The following is a description of a gene set: species: Homo sapiens Human Gene Set: PID_THROMBIN_PAR4_PATHWAY PAR4-mediated thrombin signaling events from publication Schaefer CF, Anthony K, Krupa S, Buchoff J, Day M, Hannay T, Buetow KH (PMID 18832364), and this is the list of marker genes: GNA14, F2, GNG2 (NCBI Gene Id 54331), ROCK1, MYL2, F2RL3, GNA11, GNAQ, RHOA, PLCB2, F2RL2, ROCK2, GNB1, GNA13, GNA15